Given this list of marker genes Arrb1, Dyrk1a, Ankrd28, Zmat4, Cd300a, Mup4, Serac1, Nampt, Dnal1, Kyat1, Shank3, Ark2n, Gulo, Tmem119, Scube1, Dhx33, Pax9, Ermap, Mat2a, Bpnt1, Plaat3, Oas1f, Bnc1, BC004004, Prrg3, Strn3, Pik3ca (phosphatidylinositol-4,5-bisphosphate 3-kinase catalytic subunit alpha), Ammecr1, Zfand4, Rbfox3 (RNA binding protein, fox-1 homolog (C. elegans) 3), 2310030G06Rik, Zfp941, Fam240b, Armc8, Cflar, Dusp11, Trpm3, Cstpp1, Hdhd2 (NCBI Gene Id 76987), Inhbb, Ube3d, Ntrk3, Arhgap6, Stk25, Zmat3, Hnrnpu, Tasl, Lnpk, Ano3, Scaf8, Lrrc18, Crebrf, Ifngr2, Zfp575, Deptor (DEP domain containing MTOR-interacting protein), Magi2, Mynn, Snph, Cpa6, Extl1, Bsn, Prokr1, Gipc1, Foxred2, Mettl27, Clec4a1, Cpa4, Cers3, Zc3h11a, Siah1a, Ikbkb, Kera, Kalrn, Myl10, Itga8, Npat, Rpn2, Adamdec1, Tnfrsf22, Mtx3, Dsel, Sec24c, Slc1a1, Gab2, Tbc1d30, Slc26a4, Plekhm3, Stxbp5l, Entpd7, Atp2a2, Wdr36, Samd8, Zbtb49, Cd244a, Rnf44, Zfp568, Zfp608, Ceacam19, Chtop, Grip1, Mmut, Astn2, B4galt6, Meox2, Klf10, Opn1sw, Rlig1, Nsd3, Dclre1c, Zdhhc9, Clns1a, Abcg4, Kbtbd8, Rasl12, Pcsk5 (proprotein convertase subtilisin/kexin type 5), Coq10a, Trip4, Rbm28, Homer2, Ctdspl2, Nr2c1, Gal3st2c, Scn9a, Zfp704 (zinc finger protein 704), Man2a2, Srpk2, Col3a1, Exoc6b, Agmo, Med12, Pitpnm3, Gmeb1, Slc8a1, Sumo1 (small ubiquitin-like modifier 1), Atp2b2, Matn2, Grm6, Insrr, Chst4, Cul4a, 1700012B09Rik, Erlin1, Mrpl33, Ddx19b, Hcrtr2, Scd4, Taf1, Celf3, Cd300ld (CD300 molecule like family member d), Clip3, Slc25a27, Tnks, Rufy3, Ccn6, Mtf2, Thap2, Hdac3, Slc25a23, Strn, Pum3, Dab2ip, Chmp1b, Axl, Fktn, Rad51d, Ephb2, Car8, Hadhb, Pptc7, Syt11, Gal3st2, Igfbp7, Ctsc, Dll3, Txnl4a, Slc15a1, Esr1, Urb2, Oprl1, Ddb1, Pla2g4e, Ephb3 (NCBI Gene Id 13845), Rab27b, Tmem221, Ipcef1, Fam234b, Plxdc1, Tpcn1, Zfp11, Rabgap1l, Oip5, Pdgfa, Kcnj3, Pcgf6, Usp12, Tshz2, Rgs9bp, Rassf4, Adamts5, Slc35f6, here is a description of the gene set: species: Mus musculus from publication Chen Y, Wang X (PMID 31504780) Mouse Gene Set: MIR_7021_3P Genes predicted to be targets of miRBase v22 microRNA mmu_miR_7021_3p in miRDB v6.0 with MirTarget v4 prediction scores > 80 (high confidence targets).